The following is a description of a gene set: Any process that stops or reduces the activity of a transporter. studied in species Mus musculus Mouse Gene Set: GOBP_NEGATIVE_REGULATION_OF_TRANSPORTER_ACTIVITY, and this is the list of marker genes: Grp, Kcne3, Camk2d, Kcnab1, Cav1, Mmp9, Pkd2, Drd4, Ubqln1, Kcne1, Casq2, Kcnrg, Cttnbp2nl, Stk39, Gnb5, Calm2, Ndfip2, Fmr1, Sri, 1810037I17Rik, Gpr35, Nedd4, Calm3, Kcnq1, Nedd4l, Gopc, Cbarp, Cacna1f, Osr1, Pln, Dysf, Sumo1, Ndfip1, Apoa2, Agrn, Actn2, Mrln, Calm1, Ppif, Hamp, Gsto1, Oxsr1, Tlr9, Ank3, Sln, Crbn, Wwp2, Kcne2, Nherf1, Hamp2, Gstm7, Drd2, Pcsk9, Epo, Snca, Smim6, Zfas1